The following is a description of a gene set: studied in species Homo sapiens Human Gene Set: HP_LIMB_GIRDLE_MUSCLE_WEAKNESS Weakness of the limb-girdle muscles (also known as the pelvic and shoulder girdles), that is, lack of strength of the muscles around the shoulders and the pelvis. Limb-girdle muscle weakness, and this is the list of marker genes: DOK7, MYL2, MYO9A, CHAT, COL12A1 (collagen type XII alpha 1 chain), MTAP, SGCB (sarcoglycan beta), HNRNPDL, DNMT3B, SCN4A, DAG1 (dystroglycan 1), CRYAB, DPAGT1, TWNK, LMNA, OPA1, GMPPB, MT-TE, RRM2B, POMK, PHKA1, BICD2, TPM3, FLNC, GDAP1, MAP3K20, ABHD5, SYT2, POLG, DNAJB6, BVES, LRP4, SLC25A1, DGUOK, TPM2, CHRNB1, TNNT1, TRIM32, CFL2, ACTA1, VCP, RAPSN, VAMP1, PNPLA2, ITGA7, AGRN (NCBI Gene Id 389836), CHRNE, COL6A1, MYOT, SLC25A4, GYG1, MATR3, PHKB (NCBI Gene Id 5257), CHRNA1, GALC, CRPPA, DPM3, KLHL41, SELENON, SLC18A3, LMOD3, FDX2, LDB3, PABPN1, NEB (NCBI Gene Id 4755), COL13A1, FRG1, GNE, SMN1, FKRP, ALG2, AK9, MUSK, DUX4 (NCBI Gene Id 649941), PLEC, PLIN4, GFPT1, SGCA, COL6A2, CHRND, POMT1, SMN2, SNAP25, DNA2 (NCBI Gene Id 1763), ALG14, RYR1, HACD1, LRIF1, TNPO3 (transportin 3), ANO5, POMT2, SMCHD1, DYSF, MORC2, COL6A3, MYH7, TTN, POLG2, SLC5A7, DUX4L1, PSAP, LARGE1